Given this list of marker genes Kazald1, Foxa3, Ninj2, Enpp6, Synb, Capg, Foxc2, Arhgap29, Crebrf, Lgals2, Tmem212, Wnt5a, Kcna4 (NCBI Gene Id 269325), Col6a2, Scg5, Plppr4, Arhgap6, Mia, Larp6, Papss2, Aox1, Cytl1, Pid1, Bfsp2, Cav1, Tead1, Vxn, Scg3, Bgn, Srpx2, Casp4, Vwc2, Mgp, S100a4, Gpr17 (G protein-coupled receptor 17), Mlip, Gja1, Opcml, S100a6, Shisa2, Dhrs3, Col6a1, Ddc, here is a description of the gene set: The recent identification of cancer stem cells (CSCs) in multiple human cancers provides a new inroad to understanding tumorigenesis at the cellular level. CSCs are defined by their characteristics of self-renewal, multipotentiality, and tumor initiation upon transplantation. By testing for these defining characteristics, we provide evidence for the existence of CSCs in a transgenic mouse model of glioma, S100beta-verbB;Trp53. In this glioma model, CSCs are enriched in the side population (SP) cells. These SP cells have enhanced tumor-initiating capacity, self-renewal, and multipotentiality compared with non-SP cells from the same tumors. Furthermore, gene expression analysis comparing fluorescence-activated cell sorting-sorted cancer SP cells to non-SP cancer cells and normal neural SP cells identified 45 candidate genes that are differentially expressed in glioma stem cells. We validated the expression of two genes from this list (S100a4 and S100a6) in primary mouse gliomas and human glioma samples. Analyses of xenografted human glioblastoma multiforme cell lines and primary human glioma tissues show that S100A4 and S100A6 are expressed in a small subset of cancer cells and that their abundance is positively correlated to tumor grade. In conclusion, this study shows that CSCs exist in a mouse glioma model, suggesting that this model can be used to study the molecular and cellular characteristics of CSCs in vivo and to further test the CSC hypothesis. species: Mus musculus Mouse Gene Set: HARRIS_BRAIN_CANCER_PROGENITORS from publication Harris MA, Yang H, Low BE, Mukherjee J, Guha A, Bronson RT, Shultz LD, Israel MA, Yun K (PMID 19074870) Genes from the brain cancer stem (cancer stem cell, CSC) signature.